The following is a description of a gene set: species: Homo sapiens from publication Chen Y, Wang X (PMID 31504780) Human Gene Set: MIR3064_5P Genes predicted to be targets of miRBase v22 microRNA hsa-miR-3064-5p in miRDB v6.0 with MirTarget v4 prediction scores > 80 (high confidence targets)., and this is the list of marker genes: ANKRD36, HSPB6, SORT1 (sortilin 1), ACACB, ATP1B4, CCDC186, PLXNA2, PIK3R6, RASSF8, DHCR24, CNN3 (calponin 3), PNO1, MECP2, P2RX7, MFSD11, SH3BGRL3, PIK3CB, TXNIP, KLHDC3, UBE2QL1, TRAPPC3L, ADRB1, KCNK9 (NCBI Gene Id 51305), GLDN, MYH9 (myosin heavy chain 9), IGFBP5, TCEANC2, STK38, FBXO17, SMURF1, PRDM4, EIF5, CNOT10, R3HDM4, ZNF747, BMF, ZNF12, KCNN3, ADCY1, PHF21A, CLASP2, BAIAP2L1, LZTS1, NDST1, PHLDB1, SRGAP2, PCDH20, REPS2, TBL1X, SLC26A1, MTCL2, R3HDM1, LEMD2, BAG4, CAPN6, JADE2, SLC26A9, SAV1, HEMK1 (NCBI Gene Id 51409), FZD5, CRIM1 (cysteine rich transmembrane BMP regulator 1), NECTIN4, TMEM245, IL1RL1, GABRB2, AP1M1, TNFRSF25, PAN3, MMD2, AREL1, MSRB2, SPRED2, DKK3 (NCBI Gene Id 51583), ARHGAP21, PRR15L, TBC1D16, LMX1B, AAK1 (AP2 associated kinase 1), SUMF2, PTPRJ (NCBI Gene Id 5795), ODR4, CA10 (carbonic anhydrase 10), PPP4R2, HNMT, GPN2, PRDM10, AP1G1 (adaptor related protein complex 1 subunit gamma 1), APPL2, PTPRT, GALNT10 (NCBI Gene Id 79615), ZNF74, DDX3Y, FAM107B, MRPL52, BTBD6, ZBTB3, NR4A3, FYCO1, OGT, VPS4A, SLC4A8, NUDT15, CLIP2, LRGUK, TBC1D2B, TMEM178B, RHOJ, CACHD1, RSBN1L, PIP4K2B, DNAJB9, ADD1, JOSD1, CLOCK, CLIC6, PHACTR4, ZNF544, SLC36A1, VPS33A, TFCP2L1, SIX4, ELP5, WASHC4, AGO1, CSNK1G1, HMOX2, SEZ6, CRY2, ATP10B, CIMAP2, ZNF471 (zinc finger protein 471), PPP3R1, UBIAD1, ZNF37A, RHOF, ZNF782, TANC2, PAX5, ZNF850 (NCBI Gene Id 651192), LDLRAD3, ZNF582, EDAR, EVC, ZFAND3, JPH1, CMTM4, IL1R1, IDH2